The following is a description of a gene set: studied in species Mus musculus Mouse Gene Set: GOBP_POSITIVE_REGULATION_OF_RHO_PROTEIN_SIGNAL_TRANSDUCTION Any process that activates or increases the frequency, rate or extent of Rho protein signal transduction., and this is the list of marker genes: Adgrg1, Mcf2l, Col3a1, F11r (F11 receptor), Sema4d, Akap13, Gpr55, Ngfr, Synpo2l, Apoa1, F2r, Arhgef3, Lpar2, Fermt2, Rtn4r, Robo1, Net1, Pdgfrb, Abra, Gpr4, Lpar1, Fxr1, Prag1, F2rl1, Erbb2, Csnk1a1, Plxnb1, Arrb1